Given this list of marker genes CCDC124, NAP1L1, RAB5A, ACTG1, ELOC, MYO6, BRD4 (bromodomain containing 4), AMOT, IGFBP3, DUSP5, VCL, KCNC3 (potassium voltage-gated channel subfamily C member 3), NOTCH4, FADD, ACKR3, ATP6V1E1, PRDX2, PBXIP1, RICTOR, JUN, HMGB1, CRK, AP2S1 (NCBI Gene Id 9161), BSG, CCND1, ITCH, CTNND1, COPG1, FHOD1, HDAC1, GAPDH, RHOA, RPL13A, GRB2, EEA1, NCF2, GRSF1, DNAJB9, SMARCA2, BMP10, PRKCD, SHROOM2, TAL1, MMRN2 (NCBI Gene Id 79812), SDCBP, PRKCA, EPHA2 (NCBI Gene Id 1969), RCAN1, USP10, PLCG1, MICAL2, FOXO1, DECR1, NCK1, SH2D2A, KANK1, FLNB, SSR3, PIK3R2, BIN1, YWHAE, FRS2, FJX1, NFATC2, MAPK3, MAP2K4, ERN1, CGNL1, RND1, FHL2, MMP14, DHX36, SELE, SARS1, NCF1, TUBB8, IDH2, CAMKK2 (NCBI Gene Id 121657), CLIC1, ADAM9, TNFRSF10C, MTOR (NCBI Gene Id 2476), PAK1 (p21 (RAC1) activated kinase 1), RPS6KB1, ELK1, TMSB4X, EIF2AK3, CYP2C8, PRKCZ, CDC42BPB, MAPKAP1, CLTC, ASCC3, EIF3H, ATF2, CAPZB, RHOC, PRKAA2 (protein kinase AMP-activated catalytic subunit alpha 2), ARMCX1, MEF2C, PABPC1 (NCBI Gene Id 26986), PIK3R1, TAOK2, PRKD1, ACP1, FN1, ITGB5, ROCK2, ABL1, HBD, FOXO4, AKT1, ALDOA, FLT1, TMOD3, SLC7A1, EPRS1, F3, NFATC1, KATNAL2, ALB, RAPGEF1, NR4A1, RAB11A (NCBI Gene Id 8766), PGK1, TNXB, EIF4E, NOX4, RACK1, PGF, TXN, RPL26, ZC3H15, INPP4B, DPM1, GATA2, STIP1, FXR2, PTGS2, PPP2CA, FGD5, TFCP2, ADAMTS9 (ADAM metallopeptidase with thrombospondin type 1 motif 9), CCN2 (NCBI Gene Id 1490), FGA, FGG, PTK2, QKI, EIF4G2, SEMA6D, HDAC4, APOLD1, STAT1 (NCBI Gene Id 6772), PLA2G5, TUBA1C, NRP2, PRKCB, SRC, MAP2K6, AP2A1, MMP10, NDRG1, FGB, CXCL8, TRIP4, SLC8A1, TXNIP, SPIRE1, TMSB10, MKNK1, PLOD3, TMOD1, WASF1, NR4A3, PTPN1, EPB41, BCL2, ARF4, STAM, RCN1, ARF6, CSRP2, MAPK14, DNAJA1, ELOA, BIRC5, MDM2, ARNT, SYNJ1, TFAM, ADAMTS1, NAPA, PTPN14, CFL1, BMX, MOV10, PTK2B, CALU, CAPN2, RPL7, TPCN2, TMEM170A, EIF4G1, FUT1, PLAU, SHC1, LRRFIP2, MAPK1, ATF6, DKK1, FAS, DOK1, ACACB, VEGFA, UBAP2L, ANXA1, CALR, NR4A2, P4HA2, ITGAV, PLA2G4A, BMP2, CRIP2, MAPK12, NFKBIA, HTRA1, NFKB1, GPX1, ETS1, HDAC5, CCL2 (NCBI Gene Id 6347), RHOJ, OCRL, EPS15, FAF1, CBL, GIPC1, PRKCI, PBK, PIK3CA, ITGB1, KDR, CSRP1, PTMA, RAB4A, SRF, SLC25A25, ADRB2, CTNNB1, TNFRSF25, HYOU1, EIF3F, CYCS, CYBB, FOXO3, MLST8, GRB10, CREBBP, FSCN1, EPN1, IGFBP7, MAP2K1, PXN, EGR3, TRPC3, CCN1, RELA, PSMD11 (proteasome 26S subunit, non-ATPase 11), HRAS, LMAN1, ADAM10, CTNNA1, P4HB, CCRL2, INPP5K, PLAUR, VPS39, ATF4, PPP1CA, TBCA (tubulin folding cofactor A), DLL4, RPS6, HDAC9, RPL27, ICAM1, IER5, FARSB, CSK, SLC2A14, STAT3, RPS11, DSC1, CACNA2D1, PSMD4, DNAJB4, CCT7, HSPB1, PTPN6, BCL2L1, PRKAA1, MAPK8, C15orf39, RPS6KA5, MYH11, HERPUD1, HDAC7, TRPC1, PRRC2C, FYN, RBM39, ARRB2, PRKG1, ABCF2, KL, PRKCE, DHX29, SIAH2, ACOT9, PDIA6, AKT1S1, TKT, SDF2L1, MMP2, CREB1, MYO1C, GAB1, MAP2K2, SSR4, MAPKAPK5, PTPN9, CDC42, ACACA, SET, SRPK1, ARHGEF15, ITGB3, ARPC5L, SHC2, BCAR1, CDH5, GLUD1, TRAF3IP2, VAV2, GPC1, FLII, PPM1G, MAP2K7, PPP3CA, RAF1, MAPK9, RPLP2, EWSR1, NEXN, RAP1B, NOS3, MYH9, LUC7L, SND1, RAB37, GIGYF2, SOD2, SRP54, PFN1, PRKRA, TPM3, LDB2, IQGAP1, MIR1915HG, NUMB, RAC1, FBXW11, PTPRJ, SCUBE2, NRARP, SH3BGRL3, ROCK1, CAV1, RPL10A, HSPA1A, MAP2K3 (NCBI Gene Id 92079), RPL18A, RPL5, LDHA, PDPK1, PDE4DIP, HSP90AA1, MAP3K5, PGD, HBEGF, CNP, FMNL3, EGR1, JAG1, AFDN, LIMK1, ERG, TEAD4, GSK3B, FAM120A, ENG, TXNDC5, TPP1, PTPN11 (NCBI Gene Id 84990), LRRC59, HLX, PLCB3, SHB, S1PR1, ATP6V0D1, LARP7, NCL, PRDX6, PNP, MYL2, OCLN, EPHB2, HGS, EIF2A, RAP1A, SLC25A11, PTPRZ1, EIF3D (NCBI Gene Id 8664), CHAC1, ZNF555, EZR, RCAN2, PAK2, GJA1, PRKD2, MAPKAPK2, STAT6, here is a description of the gene set: species: Homo sapiens VEGFA-VEGFR2 signaling Human Gene Set: WP_VEGFAVEGFR2_SIGNALING